Given this list of marker genes Jak2, Il12a, Canx, Il12rb2, Il27ra, Tyk2, Il6st, Ebi3 (NCBI Gene Id 50498), Stat3, here is a description of the gene set: Mouse Gene Set: REACTOME_INTERLEUKIN_35_SIGNALLING Interleukin-35 Signalling species: Mus musculus